Given this list of marker genes Rbl1, Smoc2, Nme4, Sfrp2, Gas2, Sema3f, Cdk2, Cdca4, Anxa8, Gpc3, Fam3c, Piga, Cdca7, Wdhd1, Pcna (proliferating cell nuclear antigen), Osmr, Garin5b, Sqle, Crip1, Dkk2, Cyp51, Dnm1, Cbx6, Scmh1, Rasa3, St3gal4, Kank3, Hoxa11os, Prdx4, Anp32b, Scd1, Nab1, Map3k4, Anapc5, Il1rl1, Cyth3, Prim1, Elovl6, Angptl2 (NCBI Gene Id 99355), Ercc5, Stmn1, Egr1, Msh2, Dnmt1, Crabp1, Lss, Xrcc1, Hoxa11, Acat2, Prkg2, Pml, Igf2r, Cbfb, Slbp (NCBI Gene Id 20492), Mcm2, Siva1, Agtr2, Foxp1, Man2a1, Rspo2, Hspa1a, Dnajc9, Klf4, Pold1, Slc27a3, Cdkn1a, Tipin (timeless interacting protein), Top2a, Fdft1, Ezh2, Cbx2, Slc25a15, Dok1, Pltp, Tk1, Tpst1, Pros1 (NCBI Gene Id 19128), Nfix (NCBI Gene Id 18032), Trim37, Idi1 (NCBI Gene Id 319554), Ncaph, Aqp1, Gja1, Casp2, Dnph1, Pclo, Pola1 (NCBI Gene Id 18968, polymerase (DNA directed), alpha 1), Brca2, Rab3b, Gatm, Col6a3, Areg, Mcm7 (minichromosome maintenance complex component 7), Chaf1b, Gata3, Uhrf1, Fads1, Cxcl12, Angpt2, Slk, Hjurp (Holliday junction recognition protein), H19, Gipc2, Vcan, Slc1a5, Kcnn4, Stmn2, Pdgfra, Zmym4, Idh2, Sgcd, Gsr, Sdc1, Rfc3, here is a description of the gene set: Functional inactivation of the retinoblastoma tumor suppressor gene product (RB) is a common event in human cancers. Classically, RB functions to constrain cellular proliferation, and loss of RB is proposed to facilitate the hyperplastic proliferation associated with tumorigenesis. To understand the repertoire of regulatory processes governed by RB, two models of RB loss were utilized to perform microarray analysis. In murine embryonic fibroblasts harboring germline loss of RB, there was a striking deregulation of gene expression, wherein distinct biological pathways were altered. Specifically, genes involved in cell cycle control and classically associated with E2F-dependent gene regulation were upregulated via RB loss. In contrast, a program of gene expression associated with immune function and response to pathogens was significantly downregulated with the loss of RB. To determine the specific influence of RB loss during a defined period and without the possibility of developmental compensation as occurs in embryonic fibroblasts, a second system was employed wherein Rb was acutely knocked out in adult fibroblasts. This model confirmed the distinct regulation of cell cycle and immune modulatory genes through RB loss. Analyses of cis-elements supported the hypothesis that the majority of those genes upregulated with RB loss are regulated via the E2F family of transcription factors. In contrast, those genes whose expression was reduced with the loss of RB harbored different promoter elements. Consistent with these analyses, we found that disruption of E2F-binding function of RB was associated with the upregulation of gene expression. In contrast, cells harboring an RB mutant protein (RB-750F) that retains E2F-binding activity, but is specifically deficient in the association with LXCXE-containing proteins, failed to upregulate these same target genes. However, downregulation of genes involved in immune function was readily observed with disruption of the LXCXE-binding function of RB. Thus, these studies demonstrate that RB plays a significant role in both the positive and negative regulations of transcriptional programs and indicate that loss of RB has distinct biological effects related to both cell cycle control and immune function. Mouse Gene Set: MARKEY_RB1_CHRONIC_LOF_UP Genes up-regulated in MEF cells (embryonic fibroblasts) isolated from RB1 knockout mice: chronic loss of function (LOF) of RB1. studied in species Mus musculus from publication Markey MP, Bergseid J, Bosco EE, Stengel K, Xu H, Mayhew CN, Schwemberger SJ, Braden WA, Jiang Y, Babcock GF, Jegga AG, Aronow BJ, Reed MF, Wang JY, Knudsen ES (PMID 17452985)